The following is a description of a gene set: Mouse Gene Set: GOBP_LYSOSOMAL_MEMBRANE_ORGANIZATION A process that is carried out at the cellular level which results in the assembly, arrangement of constituent parts, or disassembly of a lysosomal membrane. A lysosomal membrane is the lipid bilayer surrounding the lysosome and separating its contents from the cell cytoplasm. species: Mus musculus, and this is the list of marker genes: Chmp5, Chmp4b, Chmp2a, Laptm4b, Hspa8, Chmp2b, Laptm5, Atp10b, Chmp1a, Chmp1b2, Arf1, Chmp7, Chmp1b, Rufy4, Chmp4c, Chmp3, Chmp6